Given this list of marker genes CCNE1, CITED1, VEGFC, TGFBR1, TGFB1, FERMT2, LTBP3, here is a description of the gene set: Human Gene Set: GOBP_POSITIVE_REGULATION_OF_MESENCHYMAL_STEM_CELL_PROLIFERATION species: Homo sapiens Any process that activates or increases the frequency, rate or extent of mesenchymal stem cell proliferation.